Given this list of marker genes SLC25A6P1, SCP2D1-AS1, LCDR, CST3, EIF4E2P1, BSNDP3, CST8, RPL15P1, LINC00656, INSM1, ENSG00000225056, POLR3F, GAPDHP53, SCP2D1, LINC00261, LINC01726, RN7SL607P, MRPS11P1, NKX2-2, ENTPD6, ZNF133, VN1R108P, DTD1-AS1, RNU6ATAC34P, ENSG00000288974, FAM182B, KAT14, RNU6ATAC17P, ACSS1, VSX1, CST11, CST13P, LINC01733, RNU1-23P, CFTRP1, XRN2, LINC01432, NINL, GSTM3P1, CST9LP1, ZNF133-AS1, CST9, LNCNEF, NKX2-2-AS1, CSTP1, GGTLC1, RN7SL638P, NCOR1P1, LINC00851, CFAP61, NAPB, RIN2 (NCBI Gene Id 54453), ENSG00000306163, RN7SL690P, RNU2-56P, CSTP2, LINC01427, RNA5SP477 (RNA, 5S ribosomal pseudogene 477), LINC01721, DTD1, RN7SKP140, CD93, PET117, EEF1A1P34 (eukaryotic translation elongation factor 1 alpha 1 pseudogene 34), CST2, LINC01747, CST2P1, LINC01431, CSTL1, NXT1, ZNF337, LINC02967, LINC00652, SYNDIG1, CST1, CST9L, ENSG00000304635, BSNDP1, ABHD12, RNU6-1257P, THBD, ENSG00000304667, NAA20, KRT18P3, ZNF877P, CFAP61-AS1, DZANK1, PYGB, ENSG00000283072, RNA5SP476, POM121L3P (NCBI Gene Id 85801), MIR663A, RBBP9, RN7SL14P, KIZ, FOXA2, KIZ-AS1, MGME1, ENSG00000309956, NIPAL1P1, NANP, ENSG00000230725, ENSG00000204684, PTMAP3, MIR663AHG, RN7SL594P, RPL12P12, BETALINC1, DUXAP7, RPL41P1, RPL24P2, RNU7-137P, ENSG00000275358, LINC00237, PPIAP2, NXT1-AS1, LINC03083, CYB5AP4, GINS1, BSNDP2 (NCBI Gene Id 100422517), OVOL2 (ovo like zinc finger 2), SMIM26, CST7, CST12P, NKX2-4, CST4, GGCTP2, LINC03125, CRNKL1, SNORD17, GZF1 (NCBI Gene Id 64412), RPS19P1, LINC01727, RNA5SP479, RPL21P3, RPS15AP1, MIR3192, LLPHP1, FAM182A, APMAP, PAX1, BBLNP1 (NCBI Gene Id 133039961), RNA5SP478, CST5, SEC23B, RALGAPA2, VTCN1P1, GCNT1P1 (NCBI Gene Id 170517), RNU6-192P (NCBI Gene Id 106481237), SLC24A3, MED28P7, SNX5, ZNF337-AS1, SSTR4, CST9LP2, ENSG00000225280, SLC24A3-AS1, RN7SKP74, RPL17P1, here is a description of the gene set: studied in species Homo sapiens Human Gene Set: chr20p11